Given this list of marker genes FOXO3, HSPA1B, MIR221, INPP5D, ID2, PRKDC, HMGB2, MIR222, KAT7, MAPK11, GATA2, MAPK14, ACVR1B (NCBI Gene Id 93351), ANKRD54 (ankyrin repeat domain 54), ARNT, PRMT1, STAT3, ISG15, STAT1, FAM210B, TAL1, RHEX, BRD1, GLUL, ACVR2A, NCKAP1L, ETS1, MED1, ABCB10, GATA1, SMAP1, HIF1A, INHBA, STAT5B, HSPA1A, ZNF16, MIR486-1, here is a description of the gene set: Any process that activates or increases the frequency, rate or extent of erythrocyte differentiation. studied in species Homo sapiens Human Gene Set: GOBP_POSITIVE_REGULATION_OF_ERYTHROCYTE_DIFFERENTIATION